Given this list of marker genes ITGB1BP1, ABL1, TGFB3, APOA1, ARHGEF10, SFRP1, CCN2, ARHGEF5, LIMCH1, S100A10, CD47, TGFBR1, ROCK2, BAG4, TAC1, CCDC88A, BRAF, PPM1F (protein phosphatase, Mg2+/Mn2+ dependent 1F), RGCC, NRP1, FERMT2, LIMK1, LPAR1, CARMIL1, PFN2, EPHA1, MTOR, AMOT, SORBS3, PAK1, RAC1, FHOD1 (formin homology 2 domain containing 1), RHOA, SERPINF2, SDC4, CDC42, PPM1E, PXN, EVL, WNT4, MYOC, RHOC, TESK1, SMAD3, RAPGEF3, NF2, TACR1, ARHGEF10L, SYNPO2L, GPR65, ARHGEF15, TPM1, here is a description of the gene set: studied in species Homo sapiens Any process that activates or increases the frequency, rate or extent of the assembly of a stress fiber, a bundle of microfilaments and other proteins found in fibroblasts. Human Gene Set: GOBP_POSITIVE_REGULATION_OF_STRESS_FIBER_ASSEMBLY